The following is a description of a gene set: studied in species Mus musculus Mouse Gene Set: GOMF_METALLOENDOPEPTIDASE_ACTIVITY Catalysis of the hydrolysis of internal, alpha-peptide bonds in a polypeptide chain by a mechanism in which water acts as a nucleophile, one or two metal ions hold the water molecule in place, and charged amino acid side chains are ligands for the metal ions., and this is the list of marker genes: Bmp1, Mmp24, Adam3, Adam6b, Adam9, Adam2, Mmp19, Adam23, Afg3l2, Adam4, Spock3, Adam8, Ngf, Pmpca, Cirop, Timp3, Mmp11 (NCBI Gene Id 17385), Lmln, Atp23, Kel, Mmp21, Mmp7, Uqcrc2, Mbtps1, Mep1b, Adam34l, Adamts8, Adamts10, Adam19, Mmp12, Adamts19, Adam32, Adamts12, Mmp27, Timp2, Ide, Adamts15, Mmel1, Bst2 (bone marrow stromal cell antigen 2), Mmp10, Adamts9, Adamts1, Timp4, Adam25, Adam26b, Spock1 (NCBI Gene Id 20745), Mmp15, Adamts2, Trabd2b, Adamts6, Adamts13, Mmp14, Mmp1a, Mmp25, Mmp16, Adam22, Mmp17, Mmp9, Reck, Adam6a, Adam12, Astl, Adamts7, Mbtps2, Tll1, Adam1b, Pappa2, Fetub, Mmp3, Mmp2, Pmpcb, Ecel1, Mipep, Ece1, Adamts20, Adam33, Ybey, Mmp20, Spg7, Mep1a, Adam17 (NCBI Gene Id 236174), Rarres1, Adam5, Adam15 (ADAM metallopeptidase domain 15), Adam1a, Adamts4, Phex, Sprtn, Pitrm1, Ace, Adam10, Adamts17, Adam7, Gm4787, Adamts3, Adam24, Mmp8, Oma1, Adam39, Tll2, Adamts18, Yme1l1, Lxn, Adam11, Mmp1b, Pappa, Adamdec1, Eef1ece2, Mme, Adam34, Thop1, Adamts5, Ece2, Zmpste24, Mmp28, Rce1, Adam20, Adam18, Adamts16, Mmp13, Nrdc, Mmp23, Timp1, Adam21, Adam26a, Afg3l1, Adamts14, Adamtsl2, Adam29, Adam30, Nln, Adam28